The following is a description of a gene set: Reactome Pathway: Transcriptional regulation of brown and beige adipocyte differentiation by EBF2 studied in species Homo sapiens EBF2 (Early B-cell factor 2) is a transcription factor that marks committed brown and beige preadipocytes. EBF2 cooperates with PPARG, a master regulator of adipogenesis, to activate the brown/beige adipocyte thermogenic program (inferred from mouse homologs in Rajakumari et al. 2013). In white adipocytes, the activity of EBF2 is negatively regulated by binding of the transcription factor ZNF423, a key transcription factor for white adipocyte differentiation. In brown/beige fate-committed cells, the interaction between ZNF423 and EBF2 is impeded by BMP7, which acts as a positive regulator of brown/beige adipogenesis (inferred from mouse homologs in Shao et al. 2016; Shao et al. 2021). Direct transcriptional targets of EBF2 include PRDM16, UCP1, and PPARA genes. Other marker genes of brown/beige adipocytes, such as CIDEA, PPARGC1A, COX7A, and DIO2 are positively regulated by EBF2 and probably also direct targets of EBF2 (inferred from mouse homologs in Rajakumari et al. 2013; Wang et al. 2014; Stine et al. 2016; Shapira et al. 2017; Lai et al. 2017; Angueira et al. 2020). Based on mouse studies, EBF1 may function partially redundantly with EBF2 in regulation of thermogenesis genes. Transcriptional activity of EBF2 is positively regulated by binding of the long noncoding RNA (lncRNA) Blnc1 (inferred from mouse homologs in Zhao et al. 2014; Mi et al. 2017). Based on mouse studies, EBF2 was reported to recruit the BAF chromatin remodeling complex to activate the transcription of target genes. In addition to PPARG, based on mouse studies, EBF2 was reported to cooperate with other transcription factors such as SIX1 during brown/beige adipogenesis. Besides ZNF423, based on mouse studies, other transcription factors, such as ID1 and TLE3, have been reported to act as inhibitors of EBF2-mediated transcription. The transcription factor GATA6 was reported to directly stimulate EBF2 transcription during mouse beige/brown thermogenesis. Besides BPM7, BPM9-mediated upregulation of FGFR3, and FGF11 have been reported as indirect activators of EBF2 transcriptional activity in mouse and goat, respectively. ZAG (Zinc-alpha2-glycoprotein), a tumor secretory factor, has been reported to stimulate EBF2 expression, which contributes to white adipose tissue browning and energy wasting in cancer-related cachexia. In the single cell atlas of human white adipose tissue it was reported that the EBF2-positive hAd6 white adipocyte subpopulation with UCP1 expression, consistent with the beige profile, shows an association with increased BMI and visceral adiposity. For review, please refer to Wang and Seale 2016. part of: Transcriptional regulation of brown and beige adipocyte differentiation, and this is the list of marker genes: PRDM16, EBF2, NCOA1, RBBP7, BLNC1, ZNF423, ELOVL3, RBBP4, SMAD1, UCP1, MTA1, CIDEA, MTA3, HDAC1, DIO2, MTA2, BMP7, CHD3, PPARG, PPARGC1A, CHD4, GATAD2B, COX7A1, SMAD4, PPARGC1B, HDAC2 (histone deacetylase 2), MBD3, PPARA, RXRA, HNRNPU, GATAD2A